Given this list of marker genes SRPX2, CACNA1A, ATP1A2, SCN1A, PRRT2, YME1L1, TBC1D24 (NCBI Gene Id 57465), PSAT1, SYT1, LONP1, PDHA1, GRIN2A, here is a description of the gene set: EEG with focal sharp waves studied in species Homo sapiens Human Gene Set: HP_EEG_WITH_FOCAL_SHARP_WAVES EEG with focal sharp transient waves of a duration between 80 and 200 msec.